Given this list of marker genes XPC, MSH2, MSH6, PCNA, MSH3, PMS2, here is a description of the gene set: species: Homo sapiens Binding to a double-stranded DNA region containing an insertion or a deletion. Human Gene Set: GOMF_DNA_INSERTION_OR_DELETION_BINDING